The following is a description of a gene set: species: Homo sapiens Genes down-regulated in polarizing CD4 Th17 cells treated by digoxin: wildtype versus RORC knockout. CD4+ T helper lymphocytes that express interleukin-17 (Th17 cells) have critical roles in mouse models of autoimmunity, and there is mounting evidence that they also influence inflammatory processes in humans. Genome-wide association studies in humans have linked genes involved in Th17 cell differentiation and function with susceptibility to Crohn’s disease, rheumatoid arthritis, and psoriasis1-3. Thus, the pathway towards differentiation of Th17 cells and, perhaps, of related innate lymphoid cells with similar effector functions4, 5, is an attractive target for therapeutic applications. Mouse and human Th17 cells are distinguished by expression of the retinoic acid receptor-related orphan nuclear receptor RORγt, which is required for induction of IL-17 transcription and for the manifestation of Th17-dependent autoimmune disease in mice6. By performing a chemical screen with an insect cell-based reporter system, we identified the cardiac glycoside digoxin as a specific inhibitor of RORγt transcriptional activity. Digoxin inhibited murine Th17 cell differentiation without affecting differentiation of other T cell lineages and was effective in delaying the onset and reducing the severity of autoimmune disease in mice. At high concentrations, digoxin is toxic for human cells, but non-toxic synthetic derivatives, 20,22-dihydrodigoxin-21,23-diol (Dig(dhd)) and digoxin-21-salicylidene (Dig(sal)), specifically inhibited induction of IL-17 in human CD4+ T cells. Using these small molecule compounds, we demonstrated that RORγt is imporant for the maintenance of IL-17 expression in mouse and human effector T cells. These data suggest that derivatives of digoxin can be used as chemical probes for development of RORγt-targeted therapeutic agents that attenuate inflammatory lymphocyte function and autoimmune disease. from publication Huh JR, Leung MW, Huang P, Ryan DA, Krout MR, Malapaka RR, Chow J, Manel N, Ciofani M, Kim SV, Cuesta A, Santori FR, Lafaille JJ, Xu HE, Gin DY, Rastinejad F, Littman DR (PMID 21441909) Human Gene Set: GSE27241_WT_VS_RORGT_KO_TH17_POLARIZED_CD4_TCELL_TREATED_WITH_DIGOXIN_DN, and this is the list of marker genes: GBP4, LRIG1, LIN37, GPC3, EGR1, SCN4B, GRAMD2B, XRCC6, DESI1, VPS33B, SAV1, S100A11, MTSS1, B3GNT8, GTPBP6, HPCAL1, GTF2H4, RNASEH2C, B3GNT2, STAT6, PFKP, HSDL1, PPFIBP2, TGIF1, ATP1A1, NR4A1, PVR, SOCS3, CD3G, USPL1, SCN2B, SLC28A2, MUS81, TMEM221, AGFG2, CAMK1G, PPP1R3B, BMAL1, NFKBIA, SLC30A4, NR4A3, PODXL2, PATJ, NTN1, ABHD15, CACNB3, RGS14, EVI5L, LAG3, TRIB2, KDM1B, CD4 (NCBI Gene Id 920), AHR, XKRX, LDHB, CEACAM1 (NCBI Gene Id 634), SLC35E2A, FKBP5, SIK1, ETS2, HOXB4, FN3K, LSP1, TMIE, NSG2, CLK3, ATP9A, PMEPA1, SQOR, ARL5C, PDE4D, PLXDC1, NR1D2, ALS2CL (NCBI Gene Id 338373), CACNA1E, IRF6, TASP1, EIF4E3, SLC6A19, NAB2, SLC25A30, RASA4, EPSTI1, DRC12, SGCE, MAP4K5, INPP4B, DUSP6, BCL2L11, TNFRSF14, PLCXD2, P2RX1, TSPAN2, NFKBID, SLC7A11, RFTN1, MRAP, SMYD1, SYTL3, XBP1, NAPA, SIN3B, UROD, PAPSS2, SOCS1, RLF, LTB, PEDS1, SPRY2, TTC12, MAFF, BIN1, TXK, PIP4K2A, CLDN4 (claudin 4), CSRNP1, SELPLG, ITPKC, INSL5, LYPD6B, MYOF, SLAMF6, S100A3, AGPAT3, SLC43A1, TIMP2, GALNT7, UTP25, SPINT2, PTCRA, PRKCH, CHFR, SLC27A2, SLC16A5, XRRA1, TMC6, ARSI, TNFRSF1A, EGR2, PREP, ALCAM, AKAP12, ABCB10, ARHGAP24, OLIG3, ESYT1, TCN2, BMF, SHISA5, CXXC5, ERRFI1 (ERBB receptor feedback inhibitor 1), CSNK1E, CAMKK1, ARL4C, PTPRA, RAB3IP, EMID1, NHSL1, IL10RA, LONRF1, RALGDS, MGAT4A, EGLN1, DNAJC15, SLC37A2, PPP1R14B, SPO11, GEMIN5, KCTD1, SEMA7A, JUP, FBXW8, SMOC1, DUSP4, NRP1, CDKL1, RBM24, EVPL